Given this list of marker genes RPL27 (ribosomal protein L27), HCN4, AHDC1, ROR2, SLC12A2, GRM7, SLC25A4, CAV3, LAMB2, ATP6V1E1, FLNA, SOX9, PIK3CA, WNT4, TMEM260, NAA20, FBN1, SATB2, FLNC, SPEG, HYLS1, CHST3, HACD1, MAPKAPK5, PEX12, HDAC4, COG1, IFT27 (intraflagellar transport 27), DVL3, ZBTB7A, SMARCA4, SLC25A12, GP1BB, PEX5, CLIP2, SEC24C (NCBI Gene Id 9632), CRKL (NCBI Gene Id 1399), B3GLCT, MT-TW, PPFIBP1, NONO, DDX11, MSH2, SVBP, CAMK2A, ABL1, CTCF, MID1, FBXL4, KRAS, CEP57 (NCBI Gene Id 9702), RPL11, GNAO1, HSD11B2 (NCBI Gene Id 3291), FH, TAOK1, COLQ, FILIP1, MYH7, DYNC2LI1, PSMC1, COG7, PPP1CB, LBR, MT-TC, CIROP, ABCC9, UQCRFS1, GATA6, TAPT1, PHGDH, GTPBP3, NF1, GRIN1, IPO8, ARHGAP31, MED25, POLA1, MAP3K20, ESS2, BMPR1A, ABCA3 (ATP binding cassette subfamily A member 3), RPL35A, LTBP2, SREBF1, PLAGL1, PRDM13, RPL3L, TBX5, SMC1A, ABCA1, ATM, POLG, SFTPB, GPC3, SH3PXD2B, NHLRC2, TRAIP, SYT2, TNNI3, INSR, SKIC3, MYOCD, ESCO2, MYBPC3, POLR1A, PDHA1, COL1A2, PAH, CDK8 (NCBI Gene Id 1024), DLK1, GATA1, PKP2, DST, TRRAP, NOTCH1, ARCN1, GTF2H5, GLI3, SCN1B, MASP1, DNAJC30, ASXL1, WAC (WW domain containing adaptor with coiled-coil), BUB1B, GJA8, CDKL5, VPS33B, DMXL2, ALKBH8, NAXD, CDC45, PIEZO2, CCDC174, TRMT10C, ZEB2, ARL6, WDR37, ZIC3, SMAD2, POLE, TPM3, MKKS, DVL1, FOXF1, IFIH1, KDM6A, SMAD4, TPM2, RAC1, TSR2, ODAD3, MT-CO1, ALG12, RPL15, NSD1, VPS35L, OTUD5, TRIO, SDHB, EFTUD2 (NCBI Gene Id 9343), GPC6 (glypican 6), GATA5, CCDC47, RREB1, RPL31, DYRK1A, PSMD12, PACS2, SCN2A (NCBI Gene Id 94312), RIT1, PPP2CA, SDHA, CUX1, SALL1, TMEM94, GYS1, ATP6AP2, RNU4-2, SOS1 (NCBI Gene Id 7838), TGFB1, ALDH18A1, SELENON, B3GALT6, NEDD4L, NKX2-6 (NCBI Gene Id 137814), SMARCE1, CREBBP, JAM3, EVC2, COX16, DSG2, MGAT2 (NCBI Gene Id 4247), UMPS, MEOX1, JUP, DPYSL5, MEN1, NDUFS2, RPS28, LDLR, MYOZ2, DSP, NAE1, APOB, LRP2, CCDC32, KLHL41, ITGA7, MED13L, MYCN, FBLN5, TPK1 (thiamin pyrophosphokinase 1), SGCG, PRKACB, SLC32A1, RPS20, MIR17HG, DGCR8, CEP290, TMEM237, BAZ1B, SOX11, XYLT1, RBM8A, PCSK9, CHRM3, SCO1, KAT6A, DMD, RPS24, TAF6, SHANK3, UBR1, FBN2, TALDO1, LZTR1, PPM1D, NPPA, EXT2, GTF2I, CCDC22, GATA4, DHCR7, IGF1R, UBE3B, ADAMTS17, GTF2IRD2, RSPO2, C1QBP, FLNB, RRAGC, DTNA, DBR1, PEX14, THOC6, LONP1, NR2F2, ABCG5, GMPPB, SLC37A4, CALM3 (NCBI Gene Id 808), PEX16, TPR, TGDS, MYL2, PNKP, KAT5, LMNA, JPH2, ACVR2B, POMT1, ALPK3, GTF2IRD1, IFT81, CLXN, RPL35, WDR35, WASHC5, ZMPSTE24, MT-ND6, FCGR2A, BAP1, AARS1, GNB2 (G protein subunit beta 2), SDHAF1, FKBP6, LRP5, SPEN, TCIRG1, FIBP, MPLKIP, GDF1, BUB3, TCAP, TMEM53, VPS37D, RAD21, ATN1, DSC2, MYH6, SOX2, RNU7-1, MTX2, NEUROD2, TP63, HNRNPR, ARX, SLC25A22 (NCBI Gene Id 79751), NEK8, PKD1L1, UBR7, DEF6, TNNT2, SNRPB, PORCN, FOXC2, TRIP13 (thyroid hormone receptor interactor 13), NDUFC2, CDK13, BMP2, STX1A, PIGN, POMT2, NEXN, CD96, APC2, BMPR2, MT-TS2, WDPCP, PEX3, ERCC3, MUTYH, SETD5, KMT2D, PLD1, NIPBL, MYH3, COG6, ADAM17, ABCG8, CHD7, RRAS2, FOCAD, GPC4, POLD1, MAPK1 (mitogen-activated protein kinase 1), AXIN1, DPH1, MT-TL1, GLI1, COMT, CHD4, FZR1, METTL27, C2CD3, SIX6, PIK3R2, HYMAI, BRCA2, MMP14, EVC, ZNF699, MYLK2, BRAF, WBP4, YARS1, FANCC, MLH1, SF3B2, ENPP1, FLI1, NODAL, BIN1, ZNF687, PIGQ (phosphatidylinositol glycan anchor biosynthesis class Q), SDHD, CAPNS1, FADD, FRA10AC1, ELN, SLC29A3, TARS1, PEX26, EP300, HNRNPK, KAT6B, TTC7A, ZNF462, FGFRL1, VIPAS39, CWC27, STRA6, NSDHL, PPP2R5D, HCCS, CKAP2L, PEX19, PQBP1, DAW1, RPL9, CASK, LETM1, PTPN11, PRKACA, ERBB3, ARID1A, NDUFA11, DSG1, NIPA1, WBP11, WT1, TIAM1, PACS1, SCN5A, DPF2, SMAD6 (NCBI Gene Id 4091), BBS1, CARS1, HADHB, RTL1 (retrotransposon Gag like 1), HDAC8, MYL3, TGFB3, TRAF7, WDR26, TAB2, PEX1, DLG5, CITED2, SALL4, NDUFB11, SMG9, PMS1, TBCK, RNU4ATAC, GJA5, MOGS, MTFMT, MYRF, FTO, TRAPPC11, GTF2E2 (general transcription factor IIE subunit 2), AMER1 (APC membrane recruitment protein 1), MED12, TBX1, DOHH, ERI1, LTBP1, NOTCH3, PGM1, HOXA13, COQ4, CHMP1A, DPH2, RPS27, CCND2, ACTA1, MMP21 (NCBI Gene Id 118856), VAC14, NDUFB7, PUF60, CSRP3, RPS17, MT-CYB, RNF113A, MT-TK, BCOR, TBX20, EIF4H, STAG2, POLG2, PEX2, TET3, MAP2K1, JMJD1C, FANCB, TGFBR2, PIGA, NEK9, NDE1, CACNA1D, CACNA1C, ACTN2, NKAP, SPTBN1, GLA, ADA2, RPS29, COX7B, SLC25A20, PLXND1, MT-ND1, ACTC1, NSMCE2, EXOC2, MEG3, ACADVL, SLC25A24, YY1AP1, PLN, HEATR3, DPH5, KCNJ5, DGCR6, ZFX, SMAD3, OTUD6B, SMC3, RAI1, SPECC1L, TWNK, PEX13, RAP1B, RPL5, MGP, RPS26 (ribosomal protein S26), BTK, LEMD2, NKX2-1, LDLRAP1, RPS10, TBL2, ESPN (NCBI Gene Id 83715), TKT, RFC2, ALG9, ARSL, SMG8, RFX7, RAB23, SMARCC2, RPL26, FHL1, DEPDC5, ANKRD11, FGFR2, DGCR2, NXN, SVIL, RPS19, SLC2A10 (solute carrier family 2 member 10), BRF1, TASP1, SIK1, SEMA4A, SMARCB1, MT-CO2, ALDH1A2, CCDC28B, TBX3, ECE1, CANT1, EFEMP2, NPHP3, PLCH1, RPL18, RERE, SHOC2 (NCBI Gene Id 8036), TBC1D24, COQ9, NUP188, TTN, HADHA, GDF3, CRB2, GYG1 (glycogenin 1), RPL8, ZMYM2, MT-ND5, AKT3, CFTR, SCO2, MMP2, MICU1, PALB2, TLL1, ATRX, AGL, RAB34, GDF6, ABCC6, ARID2, ARID1B, AIP, EHMT1, DYSF, LARS2, LOX, SATB1, PPP1R13L, KDM5A, PEX11B, LRPPRC, GPR101, LIMK1, RYR1, MYPN, SLC19A2, NOD2, DNAJC19, CPLX1, AFF4, RPS7, NIPA2, NAA10, MSH6, TCTN3, STX5, MAP3K7, TNFRSF11A, B3GAT3, MAP2K2, CDH2, SON, ADAMTS19, MLXIPL (MLX interacting protein like), NUP107, MACF1, SOX4, MT-TF, STAG1, ADAMTS10, PIGP (NCBI Gene Id 53821), FNIP1, DLL4, MED23, UFD1, IGBP1, CHEK2, UBE2A, TMEM43 (transmembrane protein 43), CPT2, CTBP1, KANSL1, SEC31A, PMS2, GAA, PSEN1, TUBG1, FIG4, NEK1, KIFBP, EGFR, RARB, BCR, SYNE1, TXNDC15, JAG1, SLF2, GNPTAB, GET3, BSCL2, MT-TQ, SOS2, SGCD, PEX10, TTR, VPS13B, MEIS2, CCBE1, NOTCH2, GLRX5, MT-CO3, TXNL4A, DNMT3A, CTU2, TFAP2B, CSGALNACT1, BUB1, GJA1, NCF1 (neutrophil cytosolic factor 1), XYLT2, SCAF4, TRIM8, ALG8, ATP6V0A2, FKRP, COX6B1, MT-TV, DDX59, FGFR1, SKIC2 (NCBI Gene Id 6499, SKI2 subunit of superkiller complex), CTNNA3, SIX3, IFT56, COQ7, ATP6V1A, BUD23, SMARCD1, ARSK, EPCAM, HRAS, RRM2B, ATP13A3, NFIX, PIGL, LTBP4, EPG5, TMEM270, FANCI, TNNC1, EOGT, STAMBP, RPS15A, DYNC2I1, PRKAG2, IFT172, KAT8, KCNA1, NKX2-5, HIRA, IDH1, SMN1, ECHS1, PSEN2, KDM3B, SF3B4, ODAD1, PEX6, BRD4, PI4KA, NSD2, ERCC2, RPL10, LDB3, CHD3, ARVCF, here is a description of the gene set: Human Gene Set: HP_ABNORMAL_CARDIAC_VENTRICLE_MORPHOLOGY species: Homo sapiens Abnormal cardiac ventricle morphology An abnormality of a cardiac ventricle.